The following is a description of a gene set: species: Mus musculus Binding to a fibroblast growth factor receptor (FGFR). Mouse Gene Set: GOMF_FIBROBLAST_GROWTH_FACTOR_RECEPTOR_BINDING, and this is the list of marker genes: Kl, Fgf21, Fgf17, Fgf9, Flrt3, Klb, Frs2, Flrt2, Fgf5, Fgf18, Fgf1, Nptn, Flrt1, Fgf16, Fgf14, Fgf10, Fgf23, Fgf22, Nrxn1, Fgf15, Fgf12, Fgf4, Fgf6, Fgf20, Fgf7, Fgf3, Fgf2, Frs3, Fgf8